The following is a description of a gene set: The aggregation, arrangement and bonding together of one or more snRNA and multiple protein components to form a ribonucleoprotein complex that is involved in formation of the spliceosome. studied in species Homo sapiens Human Gene Set: GOBP_SPLICEOSOMAL_SNRNP_ASSEMBLY, and this is the list of marker genes: PRPF31, STRAP (NCBI Gene Id 11171), SNRPB, GEMIN7, RNU6-9, LSM4 (LSM4 homolog, U6 small nuclear RNA and mRNA degradation associated), RNU6-7, RNU5E-1, RNU4-2, RNU5F-1, SNRPC, RNU5D-1, SNRPE, PRP4K, SNRPF, SNRPD1, TGS1, GEMIN4, GEMIN6, SNRPD3, LSM2, DDX20, USP4, PRMT5, CD2BP2, GEMIN2, PRPF3, SART3, CLNS1A, SNRPG, GEMIN8 (gem nuclear organelle associated protein 8), SRSF12, COIL, RNU5A-1, SMN2, SART1, TSSC4, PRMT7, SNRPD2, RNU4-1, AAR2, GEMIN5, RNU5B-1, PRPF8, RNU4ATAC, SMN1, RNU6ATAC, WDR77 (NCBI Gene Id 79084), SRSF10, PRPF19, RNU6-1, PRPF6